Given this list of marker genes RXRA, PPARG, RXRG, PAX8, RXRB, here is a description of the gene set: PAX8-PPARG fusion to PPARG-mediated transcription. Pathway ID: N00126. Pathway type: Variant. Pathway class: nt06274 Thyroid cancer. Human Gene Set: KEGG_MEDICUS_VARIANT_PAX8_PPARG_FUSION_TO_PPARG_MEDIATED_TRANSCRIPTION Pathway Definition from KEGG: PAX8-PPARG -| (RXR+PPARG) studied in species Homo sapiens